The following is a description of a gene set: Any process that activates or increases the frequency, rate, or extent of fever generation. species: Mus musculus Mouse Gene Set: GOBP_POSITIVE_REGULATION_OF_FEVER_GENERATION, and this is the list of marker genes: Cnr1, Tnf, Tnfsf11, Ptger3, Il1b, Ccl5, Ptgs2, Ccr5, Tnfrsf11a